Given this list of marker genes LAT2, IGKV2-30, IGKV2D-28, FOS, MAP3K7, FYN, HRAS, PSMD2, BTRC, PSMC6, UBE2D2, IGLV2-8, IGHV3-33, RAC1, PRKCQ, TEC, IGLV1-40, RASGRP4, CDC34 (NCBI Gene Id 997), IGLC3, PLCG1, NRAS, PSMB3, TXK, PSMB4, PSMA4, PSMA5 (proteasome 20S subunit alpha 5), MAPK1, IGKV1D-16, LAT, CALM1, IGHV3-53, IGKV1D-12, PSMC3, IGLV1-44, MAP2K4, PIK3R1, PSMB6, NFKBIA, ITK, VAV1, IGKV2D-30, PSMD1, AHCYL1, PSMC2, TAB1, MAPK8, MALT1, PLCG2, IGKV3-20, FBXW11, VAV3, IGKV1D-33 (immunoglobulin kappa variable 1D-33), NFATC1, NFATC3, IGHV3-7, IGKV1-33, PSMB1, IGKV3-11, IGHV4-34, ITPR3, IGKV1-12, PSMD7, MS4A2, UBA52, UBE2N, IGHV1-46, PSMA3, PAK2, PSMC5, NFKB1, VAV2, PDPK1, LCP2, PSMA7, PSMC4, IGHV2-5, BCL10, IGHV4-59, PPP3CB, IGKV2D-40, IGHV3-48, PSMD13, UBB, LYN, RELA, BTK, JUN, MAPK10, IGHE, PPP3R1, PSMD3, IGKV3-15, TRAF6, PAK1, FCER1G (Fc epsilon receptor Ig), PSMB2, ADRM1, IKBKG, IGHV3-23, IGHV3-30, UBE2D1, PSMD6, IGHV4-39, RASGRP2, IGLV1-47, PIK3CB, CHUK, KRAS, PSMD12, SOS1, IGKV2-28, IGLV3-1, FCER1A, MAPK3, PSMA2, IGLV2-14, MAPK9, PSMA6, IGLV2-23, PSMB7, IGKV1-5, IGHV1-69, IGLV2-11, SHC1, IGHV2-70, CARD11, TAB3, MAP2K7, IGKV1-17, TAB2, IGLV7-43, ITPR1, IGHV3-13 (immunoglobulin heavy variable 3-13), IGLV3-21, IGLC2, PSMD8, IGKV1-39, MAP3K1, IGKV3D-20, PIK3R2, IGLV3-19, PSMB5, SKP1, RASGRP1 (RAS guanyl releasing protein 1), IGHV1-2 (immunoglobulin heavy variable 1-2), PIK3CA, RPS27A, ITPR2, IGKV5-2, IGLV1-51, IKBKB, IGLV3-27, IGLV6-57, PPP3CA, IGKV1-16, PSMA1, UBE2V1, NFATC2, IGLV3-25, SEM1, SYK, GRAP2, IGHV3-11, UBC, IGKV4-1, GAB2, GRB2, CUL1, PSMD11, IGKV1D-39, PSMD14, PSMC1, here is a description of the gene set: Human Gene Set: REACTOME_FC_EPSILON_RECEPTOR_FCERI_SIGNALING Fc epsilon receptor (FCERI) signaling studied in species Homo sapiens